The following is a description of a gene set: Human Gene Set: XU_RESPONSE_TO_TRETINOIN_AND_NSC682994_DN Genes down-regulated synergistically in NB4 cells (acute promyelocytic leukemia, APL) by tretinoin and NSC682994. studied in species Homo sapiens Differentiation induction is an effective therapy for acute promyelocytic leukemia (APL), which dramatically responds to all-trans-retinoic acid (ATRA). Recent studies have indicated that combinatorial use of retinoid and nonretinoid compounds, such as histone deacetylase inhibitors, arsenics, and PKA agonists, has higher therapeutic value in this disease and potentially in other malignancies. In a screen of 370 compounds, we identified benzodithiophene analogues as potent enhancers of ATRA-induced APL cell differentiation. These effects were not associated with changes in global histone acetylation and, for the most potent compounds, were exerted at very low nanomolar concentrations, and were paralleled by enhancement of some, but not all, ATRA-modulated gene expressions. Investigating the mechanism underlying the effects of these drugs on ATRA-induced APL cell differentiation, we have shown that benzodithiophenes enhance ATRA-mediated dissociation and association of corepressor N-CoR and coactivator p300 acetyltransferase, respectively, with retinoic acid receptor (RAR) alpha proteins. These data suggest that benzodithiophenes act at the level of receptor activation, possibly by affecting posttranslational modification of the receptor (and/or coregulators), thus leading to an enhancement in ATRA-mediated effects on gene expression and APL cell differentiation. Given the specificities of these low benzodithiophene concentrations for PML-RARalpha and RARalpha, these drugs may be useful for combinatorial differentiation therapy of APL and possibly other acute myelogenous leukemia subtypes in which the overall ATRA signaling is suppressed. from publication Xu K, Guidez F, Glasow A, Chung D, Petrie K, Stegmaier K, Wang KK, Zhang J, Jing Y, Zelent A, Waxman S (PMID 16140955), and this is the list of marker genes: NAE1, DDX18, RABGGTB, GRB10, EIF4E, CSE1L, ABCE1, RUVBL2, EIF3C, MYC, EIF4EBP1, EIF3B, PRMT1, DDX10